The following is a description of a gene set: Mouse Gene Set: LHX6_TARGET_GENES from publication Yevshin I, Sharipov R, Kolmykov S, Kondrakhin Y, Kolpakov F (PMID 30445619) species: Mus musculus Genes containing one or more binding sites for (Lhx6) in their promoter regions (TSS -1000,+100 bp) as identified by GTRD version 20.06 ChIP-seq harmonization., and this is the list of marker genes: Paip2b, Lipa, Ptprs, Aldh16a1, Gm19898, Mrpl9 (NCBI Gene Id 99489), Ido2, Tdrd3, Nfxl1, Eef1a1, Plbd2, Ap5z1, Mis12, Msh2, Brme1, Dusp22, Cndp2, Ksr1, 2010109A12Rik, Snhg17, 5730480H06Rik, Wfdc3, Mir6394, Cdc42, Timm10, Prkar1a (protein kinase, cAMP dependent regulatory, type I, alpha), Usp35, Poglut1, Tfg, 9230116N13Rik, Ufl1, Anapc11, B230317F23Rik, Tmem19, Zfp39, Esrrg, Nup153, 2810032G03Rik, Synm, H2-M3, Ccnd2, Rpl31, Tada2b, Aebp2, Tent4b, Lclat1, Zfp866, Rwdd2a, Plpp1, Bach1, Zzz3, Anks6, 6330549D23Rik, Rhbdd2 (rhomboid domain containing 2), Naa35, Txnip, Shox2, Dcun1d5, Cdk5rap1, Nr3c1, Mid1, Faf1, Lingo2, Bud23, Azin1, Ciart, Safb, Tm7sf3, Mapk1ip1l, Pbx3 (pre B cell leukemia homeobox 3), Eif4e, Dmac1 (distal membrane arm assembly complex 1), Txnl1, Gm11857, Strn4, Tmc6, Rab14, Cfap20, Snx15, Nipbl, Cdkn2aip, Arhgap12, Foxa3, Nfib, Ier5l, Pih1d1, Tmx2, Mir5133, Hoxa9, Trim59, 2500002B13Rik (NCBI Gene Id 78353), Nktr, Deaf1, Rpl27, Preb, Spink10, Bahd1, Camta1, Ube2r2, Kcnk2, Snhg3, Smarcc2, Cat, Tecta, Mlh3, Gabpb2, Cep57, Irf8, Sdhaf2, Cbfb, Rbm4b, Fnip2, Usp32, Mars2, Slc22a17, Utp15, Uqcc3, Klhdc10 (kelch domain containing 10), Smpd4, Naa60, Gm9922, Kat2a, Rimoc1, Hmga1, Slmap, Ptch1, Rabl3, Wtip, Pcolce2, Plxdc1, 2310022B05Rik, Hspa8, Dusp23, Rfx3, Ccdc59, Shb, Fam204a, Fmnl3, Shcbp1l (Shc SH2-domain binding protein 1-like), 2410006H16Rik, Sap25, Negr1, Ppp4r3a (protein phosphatase 4 regulatory subunit 3A), 1700003M07Rik, Ndufb5, Dcdc2a, Plk2, 2900052L18Rik, Lgr5, Rmnd5a, Scfd2, Gnb2, Gpatch8, Zfas1, Ptov1, Nr2e1, Sel1l, Maged1, Nup133, BC002059, B9d2, Ccne1 (NCBI Gene Id 12447), Golga1, Chd4, Phc3, Stx5a, Tnks2, Lancl1, H4c11, 2610027K06Rik, Gbx1, Cilk1, Osbpl5, Gm13015, Nup54, Ccni, Rab5if, Ctnna3, Nmbr, Gad1, Ubxn7, Med19, Tbc1d31, Nol6, Ddr2, Zfp422, Dip2b, Arhgef26, Zfp105, Cdc6, Sema4g, Serinc5, Atxn7, Tfap2a, Lix1l, Ryk, Ptf1a, Tecr, Ist1, Haus5, Fmn1, Ankrd17, Yes1, Oser1, Ppm1e, Mllt3, 5930430L01Rik (RIKEN cDNA 5930430L01 gene), Kdm3a, Nbn, Tmem18, Rara, Mafa, Gtf2i, Abraxas1, Zfp1006, Rpl36al, Eif5a2, 0610040B10Rik, Ak2, Med9, Otud5, Adam19, Dusp7, Lars1, Bod1l, Apc, Inpp5f, Rnf26, Kpna3, Adam9, Aifm2, Trip6, Eef1e1, Dlx1as, Slc52a2, Glt8d2, Stag1, 6430573P05Rik (NCBI Gene Id 403193), Polr1b, Zmym6, Nebl, Mir199a-1, Pnpla8, Fiz1, Mir3066, C1qbp, Msi2, Erp29, Ambn, Tnks1bp1, Dixdc1, Hdgfl2, H3c13, Sphk2 (NCBI Gene Id 97350), Igf2bp1, Gm26766, Ccdc167, Dcp2, Sec23ip, Mmut, Tubb3, Tpst2, Nfya, Kat6a, Gm7160, Ttc3, Smc6, Zfyve9, Lcorl, D030047H15Rik, Hmgxb3, Arl5a, Polr2g, Rnu11, Slc30a9, Tex14, Fbxo36, Tmem100, Mms19, Hccs, Rpl13, Gm25541, Dock4, Snord118, Tob1, Mfsd14a, Alyref (NCBI Gene Id 21681), Ilf3, 4921504A21Rik, Ppat, H3f3a, Snhg5, Virma, Tmem80, Herc3, Wasf1, H4c3, Elavl2, Rgp1, Cyb561a3, Zfp521, Ube2b, Cdc34, Nnt, Gfra1, AU040320, Hip1, Ece1, Msantd7, Patz1, Vps50, Sacs, Pxmp2, Sh3bp4, C230035I16Rik, Ap5m1, Cdc123, Xiap, Twf1, Psmb3, 5930403N24Rik, Mtmr6, Cbx2, Nt5m, Ranbp9, Capza2, Ube2m, Ube2s, Klhdc8b, Plekhg3, Zfp655, Pinlyp, Smcr8, H1f2, Sinhcaf, Slc6a16, Mbip, Rgl1, Adprh, Acaca, Abce1, Ywhae, Tanc2, Gga3, B3galt6, Tbc1d32, Sowahb, Casz1, Rab40c, Mvb12a, Ppm1b, Brd10, Mrpl45, Erlin2, Gm5464, Kat7, Mir7648, Meis2, Rft1, Arhgap31, Osbpl1a (NCBI Gene Id 64291), Snora73a (small nucleolar RNA, H/ACA box 73a), Bmt2, Polr1a, Gm17135, Klf3, Ptp4a2, Lrrc59, Tor1aip2, Tle6, Gm20485, Tmem259, Snf8, Odad3, Stk25, Cd2bp2, Gm20619, Zfp57 (zinc finger protein 57), Hnrnpu, Heca, D930048N14Rik, Rfx7, Ndrg4, Barhl1, Exoc5, Otub2, Cenpt, Car9, Srf, Kcnab2, Rnf166, Ctu2, Gm22589, Cep41, Dpysl2, Pts, Sec61a1, Svbp, Smc1a, Sp3, Pigc, Srebf2, Bckdhb, Zdhhc5, Rpa1 (NCBI Gene Id 68275), Hmmr, Arl15, Btf3l4, AI837181, Ints6l, Drap1, Mir22hg, Sema3a, Tsbp1, Ube2e2, Bmf, Kcnc3, Cyp51, Bmp2k, Hmga2, Hnrnph1 (NCBI Gene Id 59013), Klhdc2, Ctnnd1, Ppp1r15a, Zbtb18, Gstt1, Ticrr, Cbarp, Rapgef2, Atf3, Nrep, Rps2, Pip4p2, Ddx51, Tmbim4, Tmem167b, Gm11457, Tmed1, A430018G15Rik, Rgs22, Sf3b2, Ssbp4, Crnde, Atp6ap1, Foxg1, Fhod3, Rnaseh2a, Fzd4, Btbd6, Camkk2, A830082K12Rik, Cdc16 (CDC16 cell division cycle 16), 4930550C14Rik, Cdyl2, Tmco6, Zfp799, Cep170 (centrosomal protein 170), Zfyve26, Aup1, Pgd, Ccar1, Fli1, Axin2, Zfp120, Marchf11, Gm14267, Cdc40, Hcfc1, Washc4, Ccdc88a, Ube2uos, Cul4a, Ift88, Nelfa, Gm25296, Fis1 (fission, mitochondrial 1), Gm26791, 4921536K21Rik, Vps29, Proser3, Pcca, Rnaseh2b, Rnf7, Vta1, Gm13830, Smim13 (small integral membrane protein 13), Slc6a6, Med26, Dgkz, Zfp91, Miip, Rpn2, H2ac14-ps, Cdkl3, Atf6, Nr6a1os, Cnbp, Rrm1, Epn1, Hexim2, Tlx2, Tmem230, Ago2, Hnrnpll, Rap2a, Prpf38b, Tmem135, Gpr180, Chaserr, Pbx2, Adarb2, Ago1, Rbl1, Cstf2t, Morc3, Kctd7, Fads1, Antxr1, Dyrk1a, Klhl12, Zfp362, Wbp1, 1700112D23Rik, Erbb2, Mn1, Zfp292, H3c6, Bzw1, Ywhaz, Ssu72, Cenpl, Fgf4, Leprot, Pdzrn3, Mdc1, Stard5, Blnk, Ran, Ptcd2, Cep55, Svep1, Rala, Prpf18, Set, Rab11fip4os2, Klc2, Nadk2, Map3k3, Pum3, Auts2, Pcsk4, 4930589L23Rik, Aste1, Ergic2, BB218582, Pou3f3 (POU domain, class 3, transcription factor 3), Rnf38, Ash2l, Slc11a2, C030014I23Rik, Atpaf1, Ezh2, Srsf2, Med13, Isoc2a, Fam178b, Trim34a, Igf1r, Gen1, Yjefn3, Gm10461, Sema6d, Zfp560, Timeless (timeless circadian clock 1), Dysf, Xylt2, Gm20714, Morc2a, Dnttip1, Pgap2, Os9, Smyd4, Nars1, Lrp12, Ptprz1, Smchd1, Gtf2e1, Mrpl21, Glipr2, Asb1, Rxrg, Tle1, Man2c1, Trib2, Smad6, Top2a, Iqcg (NCBI Gene Id 69707), Tmem94, Wdr1 (NCBI Gene Id 28041), Alg10b, Mybbp1a, Lypd9, B230354K17Rik, Fbxo38, Enpp2, Wdr6, Ptcd3, Ss18l2, Dnajb5, Rab4b, Satl1, Cnot3, Gm1604a, Gm12841, Dclk2, Smdt1 (single-pass membrane protein with aspartate rich tail 1), Imp4, Mgat2 (NCBI Gene Id 217665), Akt2, Ribc1, Tmem79, Rragc (NCBI Gene Id 54170), Top3a, mt-Tw, Nrn1, Mir6356, Entpd7, Gm5113, Ncapg2, Pde10a, Sox9, Sart3, Slc43a2, Crlf3, Noc4l, Zfp513, Dipk1a, Mrps15 (mitochondrial ribosomal protein S15), Kpnb1, Magohb, Sars2, Nedd4 (NCBI Gene Id 639396), Elapor1, Gm12415, AW822252, Gm2093 (NCBI Gene Id 328489), Safb2, Zmym5, Pantr1, Nfkbib, Dlx1, Tra2a, Acbd5, Aagab, Taf5l, Arl4c, Mrpl2, Itpk1, Ndufs7 (NADH:ubiquinone oxidoreductase core subunit S7), Tmem41b, Med24, Rev3l, Usp42 (NCBI Gene Id 76800), Pdcd2, Dars2, Abtb3, Rhobtb3, Ndor1, Pfkl, Malat1, Mthfd1, Rnf185, Txndc12, 2610035D17Rik, Clcn7, Mettl15 (NCBI Gene Id 98892), Igfbp4, Mir1894, Spag1, Gm5475, Sap30, Sox4, 5430405H02Rik (RIKEN cDNA 5430405H02 gene), Slc25a38, Ubtf, Dsel, Tsnax, Pfas, Ypel3, Ate1, Egr1, Rbm25, Hdac5, Notch2, Rapgefl1, Gm15816, Zfhx4, 1700001L05Rik, Arpc5, Lmo7, Actg1, Psme3ip1, Maf, Lrig2, Mmgt2, E130102H24Rik (RIKEN cDNA E130102H24 gene), Pprc1, Tmed2, Ccng2 (NCBI Gene Id 12452), Smarce1, I830134H01Rik, Zfp532, Zfp143, Kras, Fam110b, Gba2, Pgbd5, Pmm2, Pknox1, Pom121l2, Golgb1, Spata17, Tada1, Gm9599, H2ac6, Hepacam2, Cc2d1a, Xpnpep3, Prss48, Gm5432, Gm11228, Mrpl49, Abat, Tsku, Eif4g1, Dtd1, Stk33, Ro60, Eif4a1, Vps26a, Samd4, Klf11, Arhgap24, Stag3, Zfp444, Rsl1d1, Mir9769, Agpat5, Nemp1 (NCBI Gene Id 72243), Gm10484, Ccdc85c, Atosb, Rnf130, St6gal2, Gm6658, Nras, Ppig, Acp6, Wdr83, Ctbp2, Ankrd46, Zfp827, Cfap276, Prr7, Lmna, Ercc6, Prkrip1, H1f4, Med9os, Wfikkn2, Ube2c, Gmeb2, Ttc9c, Cntn4 (contactin 4), Gpr176, Micu2, Gm15927, Tmem59, Srp9, Cep295, Lrrc17, Gm11536, Gm20052, Aco2, Sumo2, Neat1, Naa15, Dynll1, Tug1, Epo, Oard1, Gm4419, Fut8, Mccc1, Hmg20b, Prrc2a, A930032L01Rik, Kcnq1ot1, Lamp1, 1810044D09Rik, Flot1, Fbxl5, Gm16230, Gm24791, Akip1, Tcta, Mtres1, Auh, Slc22a23, Dnaaf9, Hace1, Hoxc9, Rpl10a, Mcm3, Sgcd, Ppm1k, Parp11, Rps29, Atp5mc2, Rccd1, Hmgb3, Mettl25, Chd9, Zfp280c, Slf2, Rab3gap2, 6330418K02Rik, Vdac3, Cyrib, Slx4ip, BB557941, Ubald2, Krcc1, 4930426L09Rik, Xrcc1, Dolpp1, Srsf1, Litaf, Cog5, Gng7, A830008E24Rik, Ube2f, Ssbp1, Fsbp (NCBI Gene Id 100503583), Hnrnpf, Rnf149, Cdca5, Cacybp, Ccnk, Stxbp6, Rabggtb (Rab geranylgeranyl transferase, b subunit), Snora64, Slc25a22, Cenpc1, H3c2, Wdr45b, Nipsnap2, Nap1l5, Tbk1, Mocs1, Depdc1b, Dlgap4, Ppwd1, Slc25a28, 4933417C20Rik, 4930449I04Rik, Procr, Gm23856 (predicted gene, 23856), Fbxw7, Zfpm1, Gorasp2, Atxn1l, Mafg, Disp1, Calcrl, Rictor, mt-Nd2, Osbp, Gm13179, Fam149b, Enoph1, Nxpe3, Raf1, Tm2d2, Gatad2b, Tmem203, Tbl1xr1, Ddx39b, 2310014F06Rik, Sfrp2, Glce, Nme1 (NME/NM23 nucleoside diphosphate kinase 1), Terf1, Tmub2, Rbm8a, Cisd2, Junos, Arhgap21, Washc2, Cdca2, Vgll4, Gm17750, Gm12454, Ecd, Hoxaas3, Snord42a, 4930558K02Rik, Fendrr, Gm16144, Pcmtd1, Psen2, Trappc6a, Zfp146, Six2, Flna, Nfkb1, Lman1, Asb9, Faap20, Gm15320, Mus81, Kif7, Mbd3, Tmem44, Zdhhc4, Gm20109, Zfp280d, Dlx6os1, Zc3h15, Ndufa6, Hbp1, Syvn1, Usp9x, Avpi1, Cacng2, Scrib, Cope, Ephb1, Rdh11, Cdh24, Klhl29, Rpl35a, Ptpa, Cetn2, Gm10644, Smim10l1, Trmt61b, Hspa4, Urb2, N4bp3, Tigd3, Atl3, Sacm1l, Tmem183a, Siva1, Gm12257, Dhps, Itpripl2, Ubtd1 (NCBI Gene Id 226122), Gm15441, Pxdn, Polr2m, Lcmt2, Otx1, Dusp18, Arhgef7, Pyroxd1, Tmtc2, E130114P18Rik, Rrp36, Snip1, Ier5, Gm13134, H3c7, Tle4, Gm9402, Fmc1, Elf3, Tshz2, Casp8ap2, Pole, Gm17031 (NCBI Gene Id 100418228), Tut1, Rcc1, Zmynd11, Kxd1, Bcas2, Rad51, Gps2, Gm11335, Pou2f1, Mre11a, Per1, Khdc4, Smurf2, Fau, Thap1, Lrch4, Dazap1 (NCBI Gene Id 70248), Metap1d, Tmem120b, Znfx1, Dicer1, Gan, Setd3, Smg5, Lss, Dus4l, Men1, Nsdhl, Coch, Pvt1, Tnrc6b, Fnip1, Supt4a, H2bc4, Aasdh, Zbtb24, Atp6v1g2, Snord45c, Tead2, Pigs, Alad, Gramd1b, 6820431F20Rik, Zbed3, Atp6v0a2, Mrps12, Dnpep, Zfp451, Get4 (golgi to ER traffic protein 4), Vps18, 2810433D01Rik, Ss18, 5730522E02Rik, Ptp4a1, Tgfbr3 (NCBI Gene Id 73753), Plscr4, Foxc2, Utp14a (UTP14A small subunit processome component), D630036H23Rik, Btbd18, Zfp597, Irf2bp2, Stard4, Setdb1, Cdnf, Ndufa10 (NCBI Gene Id 67273), Nid2, Gm16638, Nos1, Narf, Trir, Atxn7l2, Hdac2, Khdrbs1, Snord49a, 1110002L01Rik, Irx3os, Sec13, Gm16036, Steep1, Gata3os, Tnrc18, mt-Tq, 2610020C07Rik, Pycr1, Pdgfra, Luzp1, Denr, Gm25375, Dock9, Mrps27, Fgfr2, Ypel5, Cyp2j9, Mfap2, Atg4b, Foxf1, Pou2af2, Col3a1, Pcm1, Hoxc5, Lockd, Rplp0, Katna1 (NCBI Gene Id 23924), Sirt2 (NCBI Gene Id 80489), Ahcyl1, Dnali1, C230096K16Rik, Xrn1, Polr1f, Cops4 (NCBI Gene Id 52442), Rack1, Mcl1, Kat6b, Sgo2b, Nol11, Tesk2, Marcks, Polr2j, Caap1, Plekha4, Saysd1, Nsrp1, Med18, L3mbtl2, Vrk3, Kif18a, Nfat5, Reep6, Mpnd, Hspb6, Sostdc1 (NCBI Gene Id 66042), Iscu, Prdx6, H2ac4, Wwc2, Asxl2, Snhg15, Sdf4, Sox2ot, Nphp4, Hnrnpa1, Anapc16, Cpsf6, Adamts3, Gm24641, Trip12, Rbm22, Tfrc, Kctd15, Samd13, Tedc1, Mettl17, Ubac1 (ubiquitin associated domain containing 1), Trappc14, Ncor2, Zcchc2, Gab2, Ankra2, Myh14, B230119M05Rik, Hdgf, Tsen54, Sim2, Prr14, Mllt10, Msh4, Ptbp3, Prdm6, Arhgef12, Nans, Pkn2, Lyrm2, Rnf34 (ring finger protein 34), Micos10, Gli1, Gpc2, Cdc5l, Mrpl1, Gm15246, Frem1, E230001N04Rik, 5830416I19Rik, Eaf2, Gm13421, Slc44a3, Erbin, B530045E10Rik, Tspyl2, Angpt4, Mex3c, Fbxo25, Palld, Katnal2, Tmed5, 4930563E18Rik, H3f3b, Naa40 (N(alpha)-acetyltransferase 40, NatD catalytic subunit), Snord49b, Ginm1, Rpa3, Asf1b, Prkcsh, Snora78, Rhoa, Rpl18, Gnas, Hnrnpa2b1, Gnl3l, 8430429K09Rik, Gpcpd1, Slc38a2, Rmrp, Eya3, Ippk, Rps5, Rspry1, C030037D09Rik, Paics, Trim11, Adal, Pax5, Trim35, Pfkfb2 (NCBI Gene Id 75925), Acat2, 4933424G06Rik, 1700023H06Rik, 3110082I17Rik, Nprl3, Cd2ap, Mrpl17 (mitochondrial ribosomal protein L17, NCBI Gene Id 27397), Txn1, Pigp, Ppp1r10, Birc5, Snn, Rhou, Pmpcb, Csde1, 9330159M07Rik, Ppp1r15b, Snora47 (small nucleolar RNA, H/ACA box 47), Mrps7, Chchd4, Rgs9, Ypel1, Nfkbil1, Ska1, Cadm1, Smap1, Pdia4, Mgat4b, Urm1, Dhx36 (DEAH-box helicase 36), Chmp3, Dmtf1, Rad51ap2, Anxa2, Tcf7l2, Ubl3, 1700041G16Rik, Mei4, 1110020A21Rik (RIKEN cDNA 1110020A21 gene), Mir150, Gm9967, Pals1, H2ac19, Mtf1, Oip5os1, Ppil4, Pik3ip1, Pop5, St13, Rpl21-ps4, Tenm4, Pard6b, Phtf2, Nudcd2, Phyhipl, Plscr3, Rps6ka2, Dnase1l2, Get1, Ywhaq, Ivd, Snhg9, Mef2a, Srsf10, Zfp963 (zinc finger protein 963), Zfp473, Tmem116, Pank4, A130050O07Rik, AV064505, Pde4d, Psmb2, Luc7l2, Zfp846, Dph7, Rbm15b, Ncdn, Hnrnpdl, Nipa2, Bloc1s3, Tent2, Cd59b, Fbxo11, Snx18, Gm26611, 3110056K07Rik (NCBI Gene Id 73204), Esyt2, Arrdc3, Rubcn, Rbm26, Ormdl3, Brms1, Arid4a, Birc2, Tmem11, G430095P16Rik, Adnp, Mir8101, Uvrag, Vps36, Sympk, Clcn3, Snora9, Pdk3, Htra2, Ctnnb1, Cmtm6, Magi2, Tmem132c, Stau2, Lrrc75a, Ppp2r2d, Rnf103, Kctd9, Psmd5 (proteasome (prosome, macropain) 26S subunit, non-ATPase, 5), Prdm4, Actr1b, A430033K04Rik, Metap1, Tent4a, 4930405A21Rik, Ttll8, Med13l, Tubb5, Cenpk, Gm9958 (predicted gene 9958), Snhg6, Snx12, Zfp692, Nap1l4 (NCBI Gene Id 69251), Babam2, Apba1, Srd5a3, Vps16, Agl, Tecpr1, A230056P14Rik, Ccdc96, Gpatch2, Cbx3, Ldb1, Tceanc2, Asb6, Smim27, Usp47, Kmt5a, Cdkn1c, Tsc22d1, Zfp277, E530011L22Rik, Cyb5a, Caskin2, Spin1, Gorab, E4f1, Ube2d3, Polr2i, Dhx8, Tenm3, A530072M11Rik, 4930477O15Rik, Mab21l1, Gm20605, Lyrm7, Exosc4, Hif1an, Gm11917, Dek, G6pc3, Rnpc3, Calm1, Sertad1, AU015336, Prss36, Phf5a, Rbm5, Tatdn2, Uqcc5, Btaf1, Tmem43, Anapc10, Hdac4, Fbxw2, Il6st, Mir423, Rad9b, Sucla2 (NCBI Gene Id 75265), Zfpl1, Acbd4, Alkbh7, AA474408, Wdr44, Dhrs13, Derl2, Bahcc1, Nicn1, BC006965, Ldb2, Adam23, Nolc1, Pcid2, 3110083C13Rik, Etfa, Eif3l, C820005J03Rik, B4galt2, Uba1, Irak2, Ddx49, 2310040G07Rik, Rad51b, Ogt, Gipc1, Ripor2, Armcx4, Hykk, Frmd5, Trim36, Etv5, Snord68 (small nucleolar RNA, C/D box 68), Ighmbp2, Fv1, Zfp524, Kifc5b, Serbp1, Dscc1, Camk2n1, Jagn1, Agbl5, Chd2, Leng8, Mir8112, Mfsd11, Tubg1, Ndufa13, Pdik1l, Pepd, Iqch (NCBI Gene Id 78250), Cast, Pkia, Agfg2, Thoc1, Gar1, Gm15706, Vegfa, Hoxa7, Zfp974, Gm28077, Lrrc58, 2700099C18Rik, Nudt5, Myo1b, Dnajc30, Secisbp2, Fbxo24, Npas2, Slc7a6, Gsk3b (glycogen synthase kinase 3 beta), AU041133, Mllt1, Ccdc115, Ilf2, Fkbp1a, Gm16070, Umad1, Tada2a, Abcd3, E130307A14Rik, Cfap410, Tcf12, Mrps18b, Gm2670 (predicted gene 2670), 1700001G11Rik, Trpc4ap, Fbxo42, Gm14167, Igf2bp3, Avil, Dnajc13, Top2b, Retreg3, Gas2, Rny3, Mcm10, 9330151L19Rik, Thumpd1, 4930577N17Rik, Morn4, Tpd52, H4c8, Gm25878, Nr2f1, 4930539J05Rik, Tekt1, Mettl4, Cbx5, Tpi1, Gins3, H2aj, Gm11520, Map4k4, Map9, Pygo2, Ccdc18, Tbr1, Ebf1